Given this list of marker genes Unc13b, Unc13a, Rims2, Stx1b, Camk2a, Ppfia3, Rims3, Tprg1l (transformation related protein 63 regulated 1 like), Ctbp2, Rims1, Vamp2, Unc13c (unc-13 homolog C), Stx4a, Septin5, Syde1, here is a description of the gene set: The initial (indirect) attachment of a synaptic vesicle membrane to the presynaptic active zone membrane, mediated by proteins protruding from the membrane and proteins of the presynaptic active zone cytoplasmic component. Synaptic vesicle tethering is the first step in this process. Mouse Gene Set: GOBP_SYNAPTIC_VESICLE_DOCKING species: Mus musculus